The following is a description of a gene set: Genes up-regulated in bone marrow-derived macrophages treated with IL4: wildtype versus PPARG knockout. from publication Szanto A, Balint BL, Nagy ZS, Barta E, Dezso B, Pap A, Szeles L, Poliska S, Oros M, Evans RM, Barak Y, Schwabe J, Nagy L (PMID 21093321) Human Gene Set: GSE25123_WT_VS_PPARG_KO_MACROPHAGE_IL4_STIM_UP Conditional macrophage-specific PPARg knockout mice were generated on C57Bl/6 background by breeding PPARg fl/- (one allele is floxed, the other is null) and lysozyme Cre transgenic mice. PPARg and IL-4 signaling was analyzed on bone marrow-derived macrophages. Bone marrow of 3 mice per group was isolated and differentiated to macrophages with M-CSF (20 ng/ml). 20 ng/ml IL-4 was used to induce alternative macrophage activation and 1 uM Rosiglitazone (RSG) was used to activate PPARg. From each mouse 4 samples were generated: 1. M-CSF, 2. M-CSF+RSG, 3. IL-4 and 4. IL-4+RSG. All compounds were added throughout the whole differentiation process, and fresh media was added every other day. Control cells were treated with vehicle (DMSO:ethanol). After 10 days, RNA was isolated and gene expression profiles were analyzed using Mouse Genome 430 2.0 microarrays from Affymetrix. studied in species Homo sapiens, and this is the list of marker genes: ANGPTL6, CEP164, PFKFB2, RGS11, NCKAP5L, PXYLP1, DAG1, ADCY6, TMEM186, RPS6KC1, ADGRG3, RPL9, ST8SIA1, COA8, ARHGAP29 (Rho GTPase activating protein 29), KRTAP4-11, RPS7, NIM1K, TIMM8A, LAIR1, CNP, ZFYVE28, ABHD15, MRPS5, DENND1A, SLC20A1, CCR9, BEND5, ZFP2, LMAN2L (NCBI Gene Id 84746), TMIE, NME4, LRRC23, RASGRF2, GLYCTK, MSRB2, DNAH7, LYPD6B, RBM17, BRPF1, RANBP10, CAND2, GPR18, H1-2, OTUD1, DENND11, FOXP1 (forkhead box P1), RTCB, TRIO, SPHK2, RIMS3, PRRG1, FAM162B, TULP3, DMBT1, HSDL1, IFT172, PDE3B, LDLR, SLC16A12, RPS3, TSPAN9, SLC25A30, VIPR1, KIAA0040, PDE4B, QSOX2, TSEN2, TSPAN3, SFT2D3, SSBP2, ZBTB4, EFNA4, SMAD4, BPHL, CLCA1, METTL2B, ACVRL1, CAP2, H2BC18, PLSCR3, SRSF12, NPM3, SBSN, IDH2, ACOXL, GZMK, SERPINA9, AMPD1, CADM3, KDM4B, CDKL4, FGF13, IQCB1, TREML2, AFG2B, AQP11, CYP2R1, ZNF512B, USP17L2, TRIM69, ABCC2, CRTAM, PARP16, SLC25A29, PADI1, WNT5B, GUCA1B, RPL30, NXN, SELENOP, GCSH, ADH1C, CTU1, SNHG12, GPRC5B, RPL17, IRF6, TESC, PTPRF, SPRING1, TDRP, CFL2, SHMT1 (serine hydroxymethyltransferase 1), SLC26A6, CA2, CEBPZ, BRPF3, ZNF652, RPS15A, C1orf21, PATZ1, KLHL8, EEF1A2, ZNF879, SARDH (NCBI Gene Id 8017), MAN2C1, KRTAP19-5 (keratin associated protein 19-5), ALDH2, SGK3 (NCBI Gene Id 23678), RUNDC3B, SMAD7, GABRR2, MMP11, LMO4, DUSP7 (dual specificity phosphatase 7), APP, TESK2, MTHFD1, SPSB1, RAB3IP, NEDD4L, OSGIN1, LARGE1, NPC2, PATJ, DLEU7, RNF130, ZNF629, NCKIPSD, IFITM10, BRME1, MCTP2, IFT81, PARP1, DDX4, TPD52, TUBA8, AS3MT, CHCHD7, RALGPS2, TBC1D16, LBP (NCBI Gene Id 3929), TUBA4A (NCBI Gene Id 93373), PCDH1 (NCBI Gene Id 5097, protocadherin 1), TCEAL8, ZFAND2A, MYO10, ELAVL2, KLHL22, ENTPD5, DIP2C, KLHL4 (kelch like family member 4), BNC1, INSIG1, SNHG8, EYA2, ARHGAP39, UBN1, SPICE1, SPAM1, GSTK1, CEP57L1, IFI44, ZFP14, CDH1, TMEM35A, TBXA2R, SLC16A5, THADA